Given this list of marker genes ACSM1, ACSM2B, here is a description of the gene set: part of: Conjugation of carboxylic acids Reactome Pathway: Conjugation of phenylacetate with glutamine Phenylacetate metabolism is of clinical importance because its conjugation with glutamine to form phenylacetylglutamine, which can be excreted in the urine, provides an alternative pathway for nitrogen excretion in patients with urea cycle defects. This conjugation proceeds in two steps. First, phenylacetate and ATP react with coenzyme A to form phenylacetyl CoA, AMP, and pyrophosphate. Two human CoA ligases have been characterized that catalyze this reaction efficiently in vitro: acyl-CoA synthetase medium-chain family member 1 (BUCS1) and xenobiotic/medium-chain fatty acid:CoA ligase. Their relative contributions to phenylacetate metabolism in vivo are unknown. Second, phenylacetyl CoA and glutamine react to form phenyacetyl glutamine and Coenzyme A. The enzyme that catalyzes this reaction has been purified from human liver mitochondria and shown to be a distinct polypeptide species from glycine-N-acyltransferase. This human glutamine-N-acyltransferase activity has not been characterized by sequence analysis at the protein or DNA level, however, and thus cannot be associated with a known human protein in the annotation of phenylacetate conjugation. studied in species Homo sapiens